Given this list of marker genes LRRC8D, LRRC8C, GFAP, SLC25A12, NTSR1 (neurotensin receptor 1, NCBI Gene Id 4923), SLC1A4, SLC1A5, SLC1A1, LRRC8B, LRRC8A, SLC25A18, SLC1A2, SLC3A1, SLC7A13, SLC1A6, SLC25A13, UCP2, SLC1A3 (solute carrier family 1 member 3), SLC25A22, LRRC8E, here is a description of the gene set: The process in which aspartate is transported across a lipid bilayer, from one side of a membrane to the other. Human Gene Set: GOBP_ASPARTATE_TRANSMEMBRANE_TRANSPORT species: Homo sapiens